Given this list of marker genes GDF5, IDH1, DYM, EIF2AK3, GNPTAB, KIF22, COMP, here is a description of the gene set: Human Gene Set: HP_ABNORMALLY_SHAPED_CARPAL_BONES studied in species Homo sapiens Abnormally shaped carpal bones